The following is a description of a gene set: Genes up-regulated in comparison of LSK versus B cells. species: Homo sapiens from publication Konuma T, Nakamura S, Miyagi S, Negishi M, Chiba T, Oguro H, Yuan J, Mochizuki-Kashio M, Ichikawa H, Miyoshi H, Vidal M, Iwama A (PMID 21540074) Each fraction of mouse hematopoietic cells was purified by cell sorting from bone marrow of 8-week-old C57BL/6 mice, and its gene expression was analyzed. Human Gene Set: GSE27786_LSK_VS_BCELL_UP, and this is the list of marker genes: UBR7, BOD1, RUVBL1, MESD, TM9SF4, SEPTIN8, PAQR8, EXT2, KANSL1L, NAGA, MACROH2A2, TELO2, CNNM3, LAIR1, PORCN, OAS3, PDK4, NECTIN2, MAPKAP1, CCNF, MLKL, ZSCAN10, AMZ2, ZDHHC15, LDB1, KRT80, TMEM106C, ZDHHC21, ATG4C, TMBIM1, TWNK, ABCD3, SDR39U1, HRH1, METAP1D, IQGAP3, NSUN2, AIFM2, C6orf132, TOM1L1, SLC12A7, DPAGT1, NTAQ1, FAM98C, ABCA2, COQ6, IFNGR1, LRFN4, MSRA, RNF168, SELENON, RPS6KA6, SPNS3, DHX33, MCEE, ADAM22, LXN, DNAJC10, IL18RAP, IDI1, ECI2, CEP83-DT, SLC5A11, COPG1, CAVIN3, PHPT1, INAFM1, MRPS35, FAM217B, GLRX, HBZ, SLC35F5, PLCB2 (phospholipase C beta 2), PEX13, PDE6H, GSE1, TBC1D32, NICOL1, MTCL2, FLYWCH1, TNKS, UBE3B, RECK, ALDH18A1, HDAC6, SLC25A23, PDXK, HK2, CCDC120, EHBP1, NISCH, DDX56, BICDL1, PIGN, CCDC34, SSR3, UXS1, ENTPD4, TMTC3, MLST8, CSNK1E, UTP20, ENPP4, MATN2, MIGA1, CAMKK1, TCAF1, FARP2, AGTRAP, SARS2, CAD, GPRASP3, PRIM2, PTPN21, PDE9A, ARHGAP39, ST6GALNAC6, PRIM1, TRIM28, BTBD2, PAPSS1, ZNF414, UBFD1, TAS1R1, ALG2, ATP6V1G2, AATF, RAD51AP1, FBXO3, SHMT1, TLCD1, SLC66A2, ST6GALNAC5, GALNT2, ISLR, RAI2, GPR160, MCTP1, DNAJC12, TUBB6, PHF10, RPUSD1, GTF2IRD1, PRDX2, LANCL2, ADGRD1, GLOD4, CCL19, SCMH1, RIPPLY3, SLC9A9, POLE2, UBE2N, ASL, ARRB1, VILL, TGIF2, SLC25A24, FMO2, AK1, GSTK1, EIF4E3, NOP16, CASP3, MTFR1, CEP128, CHAD, SMARCC1, ACTN1, TUBB1, CA12, PWWP3B, TMEM181, EIF2B1, ANKRD26, TSC22D1, PXYLP1, ANXA11, DNMT3B, HAGHL, GSR, PUM3, CFAP68, TTC3, ORAI1, FDPS (farnesyl diphosphate synthase), SLC22A16, DYM, FCER1G, ANKH, PARD6G, MAPK14, CAP2, PDXP, GMDS, ARHGAP18, PCNX4, RUVBL2, PAICS, C8orf82